Given this list of marker genes NEUROG1, TIFAB (TIFA inhibitor), SYCP2, KLHL10, AR, CTNNB1, FGF10, RBP4, NIPBL, NPR2, DCANP1, TP63, here is a description of the gene set: The process in which the anatomical structures of genitalia are generated and organized. The genitalia are the organs of reproduction or generation, external and internal. studied in species Homo sapiens Human Gene Set: GOBP_GENITALIA_MORPHOGENESIS